Given this list of marker genes GLI2, MRPL39, HLA-DQB1, PARK7, VPS35, GM2A, TREX1, ALAD, ATXN10, FGF8, SLC2A3, PLCH1, CHCHD10 (NCBI Gene Id 400916), EIF4G1, GDAP2, NODAL (NCBI Gene Id 8114), DNMT1, EHMT1, CP, CACNA1A, SIX3, PTCH1, SPAST, LRRK2, TRANK1, VPS13A, SNCA, GAS1, BMP6, GABRB3, C9orf72, FUS, MAPK10, GRN, HTRA2, GBA1, PDGFB, MAPT, CRIPTO, VPS13C, DISP1, PSEN2, HMGCL, NOTCH3, STAG2, TMEM240, SCN1A, PRNP (NCBI Gene Id 96713), FOXH1, HTT, CHMP2B, SQSTM1, UCHL1 (ubiquitin C-terminal hydrolase L1), ACAT1, COQ2, STIL, CDON, HTRA1, PODXL, VCP, SCO2, JPH3, PRKN, PLP1, TMEM106B, TREM2, TSFM, DNAJC6, DNAJC13, TGIF1, APOE, GIGYF2, ZIC2, TARDBP, SYNJ1, CUX2, HEXA, PINK1, SHH, TBK1, PSEN1, SMARCB1, DLL1, GFAP, DCTN1, DNM1, ATP13A2, FGFR1, HFE, SMC1A, PRKAR1B, CHD2, here is a description of the gene set: Apathy Human Gene Set: HP_APATHY Apathy is a quantitative reduction of interest, motivation and the initiation and persistence of goal-directed behavior, where often the accompanying emotions, thoughts, and social interactions are also diminished. The individual is typically non-reactive to provocations, positive or negative, and appears to not care. Distinguished from lethargy which involves lack of physical or mental energy. studied in species Homo sapiens